The following is a description of a gene set: Human Gene Set: HP_HYPOPLASTIC_ILIA studied in species Homo sapiens Underdevelopment of the ilium. Hypoplastic ilia, and this is the list of marker genes: SMAD4, PCYT1A, LAMA5, PCNT, FLNB, ERCC6, RNU4ATAC, MEG3, B3GALT6, TBX15, FLNA, RPS19 (NCBI Gene Id 8378), DYM, COL11A1, TRAPPC2, NKX3-2, INPPL1, SOX9, EP300, HSPG2, WDR19, RTL1, RIPK4, WNT7A, ARSB, IFT81 (intraflagellar transport 81), EED, COL9A1, LYSET, CCBE1, TMEM67, COL11A2, SLC26A2, EZH2, CREBBP, POP1, EVC, DLK1, HDAC6 (histone deacetylase 6), KAT6B, POLR3A, SLC35D1, ACP5, COL2A1, RMRP, EVC2, MAN2B1, IHH, CTSK, FGFR3, LIFR, FN1, RUNX2, ERCC8